The following is a description of a gene set: species: Mus musculus The regionalization process in which specific areas of cell differentiation are determined along the anterior-posterior axis. The anterior-posterior axis is defined by a line that runs from the head or mouth of an organism to the tail or opposite end of the organism. Mouse Gene Set: GOBP_ANTERIOR_POSTERIOR_PATTERN_SPECIFICATION, and this is the list of marker genes: Hoxb6, Wnt3, Rbpj, Htt, Fgf8, Pbx1, Osr1, Abi1, Mib1, Hoxd3, Hoxd11, Hoxa10, Myf6, Srf, Six3, Tulp3, Tcap, Sox17, Gdf11, Hes1 (NCBI Gene Id 15205), Fuz, Ripply2, Hoxa1, Hoxb3, Smad2, Tgfbr1, Ror2, Ddit3, Hes5, Sf3b1, Ets2, Gli2, Hes7, Tshz1, Hoxa11, Tdrd5, Gdf3, Ripply1, Tcf15, Hoxc8, Wnt2b, Palb2, Med12, Zic3, Atp6ap2, Helt, Bhlhe41, Neurog1, Dll1, Wnt3a, Six2, Hes2, Taf10, Otx1, Foxh1, Smad3, Bptf, Hoxa5, Rnf2, Pld6, Hipk1, Prickle1, Xrcc2, Psen1, Atm, Hoxb9, Fzd5, Hes6, Pax1, Msgn1, Nkx3-1, Meox1, Wnt8a, Sfrp1, Ssbp3, Celsr2, Ring1, Hoxd9, Aldh1a2 (aldehyde dehydrogenase family 1, subfamily A2), Cdx4, Wnt2, Fezf1, Bmpr1a, Pgap1, Grsf1, Celsr1, Myf5, Pcsk6, Prkdc, Lefty1, Pcsk5, Hoxa9, Nr2f2 (nuclear receptor subfamily 2, group F, member 2), Wnt5a, Ldb1, Wt1, Tdrkh, Cfc1, Tbx1, Cripto (NCBI Gene Id 235635), Bmi1, Foxb1, Tcf7l1, Hoxc10, Btg2, Bmp2, Tdrd1, Kmt2a, Frs2, Hoxc9, Yy1, En1, Lrp5, Hoxa7, Hoxb8, Gbx2, Hoxc6, Trp53, Dmrt2, Foxc2, Mesp1, Nle1, Rarg, Ifitm1, Sema3c, Crb2, Tbx6, Cobl, Hoxd8, Hoxd10, Cdx1, Tasor, Gpc3, Dll3, Foxa2, Hey1, Ctnnb1, Foxc1, Crkl, Pax6, Hoxd13, Zeb2, Neurod1, T, Hoxc11, Nrarp, Tbx18, Ttn, Msx2, Bmpr2, Nckap1 (NCK-associated protein 1), Hes3, Tifab (TRAF-interacting protein with forkhead-associated domain, family member B), Cyp26a1, Psen2, Alx1, Cyp26c1, Lefty2, Barx1, Hoxc4, Hey2, Nodal, Bmp4, Heyl, Epb41l5, Hoxc5, Vangl2, Emx2, Apc, Hoxb7, Kdm6a, Pcdh8, Ski, Hoxa2, Gli3, Notch1, Hnf1b, Sfrp2, Scmh1, Lrp6, Smad4, Cer1, Hoxc13, Lhx1, Gata4 (GATA binding protein 4), Hoxa4, Zbtb16, Hoxd4, Ppp2r3a, Msx1, Wnt1, Ep300, Nog, Foxf1, Pcgf2, Pofut1, Hoxa3, Poglut1 (protein O-glucosyltransferase 1), Ctnnbip1, Cdx2, Hipk2, Hoxb4, Kif3a, Tdrd7, Ift88, Wls, Otx2, Hoxa6, Kat2a, Mesp2, Hoxb2, Mllt3, Hoxb1, Aurka, Shh, Kdm2b, Hhex, Alx4, Lfng, Plxna2, Axin2, Tbx3, Arc, Tmed2, Cdon, Hoxb5, Pax3, Tdrd6, Lef1, Acvr2b, Pds5a, Meox2, Fezf2, Bhlhe40, Acvr2a, Dkk1, Ofd1, Smo